Given this list of marker genes GLB1, MAN2B1, LYST, CLN5 (CLN5 intracellular trafficking protein), AGA, NEU1, PNPLA2, SLC17A5, CLN3, FUCA1, PPT1, here is a description of the gene set: The presence of clear, sharply defined vacuoles in the lymphocyte cytoplasm. Vacuolated lymphocytes Human Gene Set: HP_VACUOLATED_LYMPHOCYTES studied in species Homo sapiens